Given this list of marker genes Ephb3, Gpsm1, Vav2, Mmut, Sh3bp1, Odam, Tax1bp3, Ptk2b, Gpr137b, Ntrk2, Rsu1, Sema4d, Rapgef6, Lars1, Rasip1, Nedd9 (NCBI Gene Id 319669), Prtn3, Slc27a4, Rdx, Epha3, Mex3b, Ntrk1, Rab3gap1, Wdr41, Tgm2, Itgb1, Rap1a, Ajuba, Pkp4, Arhgef16, Rack1, Arhgap42, Ralgapa2, Arhgef19, Scrib, Map4k4, Cblb, Ripor2, Gpr65, Dvl2, Foxj1, Bves, Plxnb2, Itga6, Wnt11 (wingless-type MMTV integration site family, member 11), Tns3, Ccr7 (NCBI Gene Id 12775), Dab2ip, Rasgrf1, Sod1, Syde1, Zc3h15, Sgsm3, Arhgap6, Thy1, Gsk3b, Adcyap1, Abr, Rgs8, Rgma, Plxnb3, Rasgrp1, Spry1, Usp6nl, Evi5, Ralgapa1, Dgki (NCBI Gene Id 320127), Rapgef3, Pafah1b1, Chn1, Mlst8, Rap1gds1, F2rl1, Grhl3, Dock7, Rgs16, Efna5, Arhgef7, Tmed2, Tbc1d10b, Ccl26, Ccl24, Lrrk2, Ccpg1, Rgp1, Mkks, Crk, Bcr, Ccdc125, Tsc1, Rasgrp2, Tbc1d15, Stmn1, Snx18, Epha2, Arfgef1, Fermt2, Snx9, Epha4, Itgb1bp1, Sh3bp4, Bcl6, Mtss2, Rrp1b, Als2, Pin1rt1, Rcc2, Agrn (NCBI Gene Id 381587), Rtn4r, Dennd1a, Rab11fip2, Tbc1d2, Arap1, Ntf3, Arhgap1, Vav1, Dennd1b, Epha1, Rgs1, Usp17le, Pot1b, Cxcl13, Kalrn, Spry2, Arhgef5, Nf1, Arhgap11a, Smcr8, Ttc8, Apc2, Arhgef10, Net1, Arhgap35, Plxnb1, Ccl11, Wnk1, Sgsm2, Cav2, Rhog, Fgd1, Rasgrp3, Arhgap24, Rgs10, Evi5l, Vav3, Arl2, Mtor, Dock11, Met, Ralbp1, Ezh2, Gmip, Arhgap44, Coro1c, Rab3gap2, Bcar3, S100a10, Tbc1d20, F2r, Prom2, Rapgef1, Tiam1, Ripor1, Dvl3, Wnt4, Cd40, Pip5k1a, Mapre2, Myo9b, Crkl, Prex1, Ntrk3, Rangap1, Adap1, Prkg1, Hras, Tbc1d30, Asap3, Dock10, Srgap2, Ngef, Pin1, Lims1, Wnt5a, Rictor, Epha5, Rgs7, Rapgef2, Dock9, Ralgapb, Ndel1, Amot, Snx13, Rap1gap, Ric1, Ect2, Dock8, Gnb5, Lrch1, Pycard, Ccl19, Sipa1l1, Rgs6, Rgs14, Bbs4, Tbc1d7, C9orf72, Akt2, Rabgap1, here is a description of the gene set: studied in species Mus musculus Mouse Gene Set: GOBP_REGULATION_OF_GTPASE_ACTIVITY Any process that modulates the rate of GTP hydrolysis by a GTPase.